Given this list of marker genes Cyfip1, Fchsd2, Abi2, Wasf1, Fmn1, Scin, Magel2, Wasf3, Nckap1, Gsn, Brk1 (BRICK1, SCAR/WAVE actin-nucleating complex subunit), Wasf2, Wmp, Trim27, Whamm, here is a description of the gene set: studied in species Mus musculus Mouse Gene Set: GOBP_POSITIVE_REGULATION_OF_ACTIN_NUCLEATION Any process that activates or increases the frequency, rate or extent of actin nucleation, the initial step in the formation of an actin filament in which actin monomers combine to form a new filament.